The following is a description of a gene set: Genes up-regulated in effector CD8 T cells at the peak expansion phase (day 8 after LCMV-Armstrong infection) compared to effector CD8 T cells at contraction phase (day 15 after LCMV-Armstrong infection). from publication Kaech SM, Hemby S, Kersh E, Ahmed R (PMID 12526810) studied in species Homo sapiens Human Gene Set: KAECH_DAY8_EFF_VS_DAY15_EFF_CD8_TCELL_UP How and when memory T cells form during an immune response are long-standing questions. To better understand memory CD8 T cell development, a time course of gene expression and functional changes in antigen-specific T cells during viral infection was evaluated. The expression of many genes continued to change after viral clearance in accordance with changes in CD8 T cell functional properties. Even though memory cell precursors were present at the peak of the immune response, these cells did not display hallmark functional traits of memory T cells. However, these cells gradually acquired the memory cell qualities of self-renewal and rapid recall to antigen suggesting the model that antigen-specific CD8 T cells progressively differentiate into memory cells following viral infection., and this is the list of marker genes: DLGAP5, HM13, GZMB, NDUFB5, SPDL1, CORO1C, SRP14, PTPA, CCNB2, CRYM, TXN, STMN1, PHB2 (prohibitin 2), LAGE3, KIF4A, RAC2, ALDOA, CNDP2, ATP5PF, LGALS9B, HTATIP2, NANS, PRC1, PSMA5, DCPS, PERP, LMNB1, CDKN2C, G6PD, PDCL3, SSNA1, PUF60, BATF, DPP8, TRDMT1, MBD2, NDUFA4, E2F8, DDT, TIMM13 (NCBI Gene Id 26518), RACGAP1, NDUFB9, SGCB, PCLAF, DAP, NUDT21, NDUFV2 (NADH:ubiquinone oxidoreductase core subunit V2), LRRC8C, USP18, REEP5, EIF3C, BANF1, ADAM8, RPN1, PSMC1, LIG1, MED28, IGBP1, EIF3D, GGH, INTS9, TNFAIP8L1, F2RL3, PLAC8, TOP2A, YBX3, ROM1, SRP68 (NCBI Gene Id 96239), NAT1, PSMA2, MRPL42, NUDT1, EEF1AKMT1, NCBP1, TBRG1, MKI67, PPIB, MYCBP, CD48, PSMB6, PTGR1, EIF3K, TYMS, COX16, KIF11, RRM1, BTF3, EMC3, CMC2, NCAPH, CASP7, UBL5, ETFB, ACSL5, NFE2, HK2, AP3S2, CDC45, WDR83OS, CKS1B, POMP, TAGLN2, CDC25C, C3orf38 (NCBI Gene Id 285237), LGALS1, DDOST, TCF19, CDC20, SSR1, DHRS1, LDHA, CDK1, ISYNA1, PRELID1 (NCBI Gene Id 27166), AIP, MRPL30, NDUFA8, USP3, GZMK, AK3, COX17, CCDC12, COIL, SELENOH, FDPS, CTNNA1, GYG1, LAMTOR1, CIB1, HIKESHI, LGALS3BP, LAMTOR5, IQGAP3, ERGIC3 (NCBI Gene Id 51614), WASHC3, GLRX (glutaredoxin), ACOT9, ARL6, ASF1B, ACOT7, ADPRH, ANXA2, DBI, PPP2R5C, RNASEH2B, CPT1A, NELFCD, SMAP1, TUBB, ELOA, SUGT1, BIRC5, MCM5, TXNDC17, YWHAG, RPL13A, GSTT2, GNPDA1, PSMD8, MRPL27, CDCA5, KIF22, WDR1 (WD repeat domain 1), PRRC1, XDH, SEM1, ARHGDIB, REPS1, MNS1, MRPS17, HMGB2, SLC66A3, PRIM2, CDC34, PGLYRP1, LXN, MRPL41, TACC3, NUSAP1, SH2D2A, FAM89B, LGALS3, PRDX1, CCNA1, RPSA, COMMD1 (NCBI Gene Id 150684), MRPL43, PMM1, PLP2, ATP5IF1, SLC25A4, NDUFB6, RRM2, CMAS, COX6C, ERG28, FRG1, QNG1, ANXA6, ATP5PB